Given this list of marker genes GJA1, GDF5, COG4, PTH1R, ZMYM3, IDH2, SHOX, IDH1, NIN, here is a description of the gene set: species: Homo sapiens Madelung deformity An anomaly related to partial closure, or failure of development of the ulnar side of the distal radial growth plate, which results in an arrest of epiphyseal growth of the medial and volar portions of the distal radius. This leads to shortening of the radius and relative overgrowth of the ulna. Human Gene Set: HP_MADELUNG_DEFORMITY